The following is a description of a gene set: Human Gene Set: MIR3134 from publication Chen Y, Wang X (PMID 31504780) species: Homo sapiens Genes predicted to be targets of miRBase v22 microRNA hsa-miR-3134 in miRDB v6.0 with MirTarget v4 prediction scores > 80 (high confidence targets)., and this is the list of marker genes: SH3TC2, OLA1, HECW2, SKP1, CASP10, SPA17, INTS6, TMEM132C, TGIF2-RAB5IF, PDE6A, ITGA1, PRAMEF1, PCBP2, ZNF227, GARIN6 (golgi associated RAB2 interactor family member 6), MID2, DCX, SPATA6, EOGT, RPS6KL1, ZNF664, TMEM265, SPHKAP, CD1E, DCLK1, DENND11, NCOA2, MYLK4, HSPB8, PLEKHG2, FAM169BP, NRXN1, ANTXR1, DIS3, KRT4, TRIM49, UTP25, BTNL9, SEMA4D, PLBD2, TRIM49C, ANGPTL1, RHBDD1, RAB5IF, CNTN5, FAM217A, IFNA2, CNTD1, TOB1, MCTS1, CT62, ALG10, KIF5C, ARHGAP11A, FUS, IGF2, ST8SIA2, DPH3P1, NT5E, ADGRL3, NAA50, DLX2, ABHD17C, KPNA4, C5AR2, NUDCD1, EMCN, AMMECR1, THAP6, TRIP11, MYCT1, SV2B